Given this list of marker genes PSMD9, PSMC3, PSMD13, PSMD8, PSMB5, PSMD11, ADRM1, PSMA7, PSMC5, PSMB3, PSMA4, PSMA6, PSMD12, PSMA1, PSMD14, PSMB7, PSMB6, PSMD2, PSMB4, PSMB2, PSMC2, PSMB1, PSMA5, PSMA3, PSMA8, PSMA2, PSMD3, PSMC1, PSMC4, APP, PSMD7, PSMD1, SEM1, PSMD6, PSMD4, PSMC6, here is a description of the gene set: Human Gene Set: KEGG_MEDICUS_VARIANT_MUTATION_CAUSED_ABERRANT_ABETA_TO_26S_PROTEASOME_MEDIATED_PROTEIN_DEGRADATION Mutation-caused aberrant Abeta to 26S proteasome-mediated protein degradation. Pathway ID: N01060. Pathway type: Variant. Pathway class: nt06460 Alzheimer disease. Pathway Definition from KEGG: APP* -> Abeta -| 26S studied in species Homo sapiens